Given this list of marker genes COLEC11, CRTAM, CCL19, B4GALT1, OVGP1, LBP, PRSS55, ADAM18, TNFRSF21, CD9, CNTNAP3, EXT1 (exostosin glycosyltransferase 1), CDK5R1, CADM1, CASP3, VCAN, SPAM1, HAVCR2, ATP8B3, DCST1, FOLR1, GARIN3 (golgi associated RAB2 interactor family member 3), ARHGAP35, FOXG1, NDN, CCR7, IGSF9, TUB, FOLR3, DCST2, SPACA6, COLEC12, ROBO4, PAEP, CFP, DLG1, IZUMO1R, FCN2, FCGR1A, CD209 (NCBI Gene Id 30835), NCK2, MBL2, ZPBP2, HSPA1L, EPHA3, CCT2, FCN1, EFNB3, PCSK4, CCT8, CCT3 (chaperonin containing TCP1 subunit 3), GIT1, CRP, AMIGO1, SPA17, COLEC10, TNN, ALDOA, CNTNAP2, MYPN, PEAR1, CD81, TMEM81, ZP3, JMJD6, YWHAZ, ZP1, CNTN4, CNR1, CD5, CORO1A, SPACA3, ST6GALNAC6, FUT3, TEX101, PCDHA7, CLEC7A, CCT5 (chaperonin containing TCP1 subunit 5), PECAM1, BSG, FEZF2, RTN4, EPHA4, SEMA5A, NRP1, DSCAM, NRCAM, NEXN, ADGRB1, C4BPB, NEDD9, NPTN, SPACA4, CRISP1, CD36, MEGF8, CLGN, APP, DOCK8, FOLR2 (folate receptor beta), ACR, PTX3, C4BPA, ADAM32, EPHB1, FREY1, CNTN2, CCL21, ZP2, FCN3 (NCBI Gene Id 8547), MYO18A, LGALS3, ROBO1, CD2AP, NTM, ROBO2, GAP43, EPHB3, PCDH12, TULP1 (NCBI Gene Id 7287), SPPL2C, PLA2G5, TREM2, ROBO3, SCARB1, IZUMO1, CLEC4M, CRTAC1, ZAN, CD6, NCAM2, MSN, PRSS37, CCT4, ZPBP, VDAC2, CNTN6, NCR3, OPCML, DSCAML1, EMB, SPESP1, CD226, PALLD, ASTL, LY6K, EPHB2, ZP4, UBAP2L, TMPRSS12, TCP1 (NCBI Gene Id 6950), PRF1, CCT7, PLXND1 (NCBI Gene Id 23652), C4B, SPON2, DOCK2, MEGF10, SFTPA1, PCDHB6, ADAM2, FETUB, here is a description of the gene set: Human Gene Set: GOBP_CELL_RECOGNITION studied in species Homo sapiens The process in which a cell in an organism interprets its surroundings.